Given this list of marker genes Pla2g1b, Etnppl, Smpdl3b, Pla2g4e, Pld2, Pla2g7, Inpp5f, Pla2g2c, Pla2g4f, Pla2g4d (phospholipase A2, group IVD), Napepld, Apoa2, Plcg1, Gdpd1, Gpcpd1, Abhd16a, Smpd1, Enpp7, Angptl3, Abhd6, Ldlr, Lipc, Smpd2, Pnpla8, Plcg2, Smpdl3a, Prdx6b, Plcb1, Abhd12, Plcb3, Pla2g15, Plpp6, Pnliprp2, Abhd12b, Smpd5, Prdx6, Pla2g4c, Gdpd3, Pla2g10, Pla2g6, Prkcd, Smpd4, Apoc2l, Scarb1, Pla2g4b, Smpd3, Apoc1, Plbd2, Enpp2, Plb1, Pnpla7, Apoc2, Pla2g5, Pla2g4a, Pld1, Idh1, Plbd1, Abhd16b, here is a description of the gene set: The chemical reactions and pathways resulting in the breakdown of phospholipids, any lipid containing phosphoric acid as a mono- or diester. Mouse Gene Set: GOBP_PHOSPHOLIPID_CATABOLIC_PROCESS studied in species Mus musculus